The following is a description of a gene set: Genes having at least one occurrence of the motif NNNNNNRGNACNNKNTGTTCTNNNNNN in the regions spanning 4 kb centered on their transcription starting sites. This matches the PGR transcription factor binding site V$PR_02 (v7.4 TRANSFAC). studied in species Homo sapiens Human Gene Set: PR_02, and this is the list of marker genes: KCTD4, MPC2, EEF1B2, LRRTM3, LARP4 (La ribonucleoprotein 4), DOCK4, LOX, KLHL5, TECTA, SKIL, SPATA31G1, FSTL5, PYGM, BDNF, NDST2, SYNCRIP, CD101, OPN3, ZNF277, RELCH, NIPBL, RAB30, TRIM63, OTP, KRT20, RGS3, KRTAP11-1, NCKAP5, ELF5 (E74 like ETS transcription factor 5, NCBI Gene Id 2001), SMOX, ETS1, WNT8B, NCDN, ADAMTSL1, NLK, ZMYND8, SRGN, DUSP10, ZNF395 (NCBI Gene Id 55893), MBP, CDKN1A, FRA10AC1, TBL1XR1 (TBL1X/Y related 1, NCBI Gene Id 81612), DSTN, MAP1B, XPNPEP3, RAB1B, SEMA3A, DLG3, CA5B, SCNN1A (sodium channel epithelial 1 subunit alpha), MIR7-3HG, TIMD4, FES, ZP3, CALCRL, AKAP3, LUC7L3, USP54, UVRAG, SREK1, ITGA6, EIF4ENIF1, SDC1, OTX2, GRB2, WT1-AS, PDZD9, FGF17, DLX2, BCL6, ST13, KHDRBS1, IKZF2, RERE, CD52, EPHA7, WNT4, ID3, SH2D1A, ELMO1, PDGFB, JPH1, NSD1, RTL3, LGI1, ADNP, PACS1, PIGV, SEMA4C, PXN, RNF38, MYH4, ZFHX4, KCNH5, FIGN, NDUFS1, DOLPP1, CPB1, AMY2A, STK35, ACBD3, IP6K2, CCDC126, FBXO9, VCPKMT, KCNK10, SLC7A8, PRRX1, TNS2, HAUS4, CD36, GABRA6, LAMA4, PHC2, NEDD4, EPG5, RBM3, PROX1, ADCY6, SPTBN1, CXCL14, ATF7IP, DST, UBE2B, CPEB4, OTX1, RANBP9, ZNF654, ARHGAP6, MPZ, SOX5, SMPX, KCNJ1, RWDD1 (RWD domain containing 1)